Given this list of marker genes NDUFB1, STX6, CDC42EP4 (CDC42 effector protein 4), RBFOX2, STAT6, FCHSD2, KAT6A, KLHDC9, ZKSCAN2, CABIN1, TCF3, ATP5MF-PTCD1, SNHG7, SMG7, UBC, CASC3, GOLM2, CNTNAP2, DHX33-DT, BRWD3, SMG7-AS1, CPSF2, ATP5MF, PTCD1, SRFBP1, MIR5188, LINC02960, INTS12, MTF2, RNU11, CALM3, GSTCD, DCP1A, PPP6R1, ARHGAP24, GBA1, DRG2, SMAP2, JPX, NOP16, TSEN15, KDM1A, LINC01132, PPP5D1P, RNF220, SMARCD2, CCN1, DHX33, here is a description of the gene set: from publication Yevshin I, Sharipov R, Kolmykov S, Kondrakhin Y, Kolpakov F (PMID 30445619) species: Homo sapiens Human Gene Set: ZSCAN18_TARGET_GENES Genes containing one or more binding sites for (ZSCAN18) in their promoter regions (TSS -1000,+100 bp) as identified by GTRD version 20.06 ChIP-seq harmonization.